The following is a description of a gene set: Inhibition of the reactions brought about by dioxygen (O2) or peroxides. Usually the antioxidant is effective because it can itself be more easily oxidized than the substance protected. The term is often applied to components that can trap free radicals, thereby breaking the chain reaction that normally leads to extensive biological damage. studied in species Mus musculus Mouse Gene Set: GOMF_ANTIOXIDANT_ACTIVITY, and this is the list of marker genes: Prdx3, Gstp3, Prdx6, Ltc4s, Hbq1a, Prdx2, Selenos, Ptgs2 (prostaglandin-endoperoxide synthase 2), Cat, Gstt2, Prdx4, Lrrk2, Gsr, S100a8, Apom, Gpx7, S100a9, Gstp1 (glutathione S-transferase, pi 1), Ubiad1, Gpx1, Tpo, Sesn2 (NCBI Gene Id 230784), Hba-x, Trp53inp1, Prdx1, Gstp2, Gpx6, Park7, Cp, Sod3, Epx, Hbb-bh1, Sod2, Gstk1, Txnrd3, Txnrd2, Ambp, Cygb, Apoe, Lpo, Gstt1, Mpo, Gstm7, Upk3bl, Gpx2, Nqo1, Mgst1, Hp, Txndc17, Prxl2a, Hba-a1, Sod1, Hbb-y, Hbb-bs, Hbb-bh2, Mgst3, Ptgs1, Hbb-bh0, Srxn1, Gpx5, Txndc2, Hbb-bt, Mb, Selenow, Gstp-ps, Apoa4, Txnrd1, Gsto1, Selenof, Fabp1, Gpx8, Gsta13, Prdx5, Gpx4, Prxl2b, Gpx3, Gsto2, Gsta5, Gsta1, Hba-a2, Gsta2, Hbq1b, Kdm3b, Prdx6b (NCBI Gene Id 320769), Pxdn, Nxn, Alox5ap, Selenot, Ptges, Mgst2